The following is a description of a gene set: species: Mus musculus Any process that stops or reduces the rate of peptidase activity, the hydrolysis of peptide bonds within proteins. Mouse Gene Set: GOBP_NEGATIVE_REGULATION_OF_PEPTIDASE_ACTIVITY, and this is the list of marker genes: Csta1, Gapdhrt2, Serpinb9f, Serpinb8, Cst3, Stfa3, Bin1 (bridging integrator 1), Ecm1, Serpinb6a, Serpinb1c, Spock3, Wfdc6a, Serpinb9b, Timp2, Gapdh, Spink1, Gapdh-ps15, Cstdc4, Serpinb9e, Park7, Stfa1, Vtn (NCBI Gene Id 22370), Serpinb6c (serine (or cysteine) peptidase inhibitor, clade B, member 6c), Timp1, Ubxn1, Stfa2, Timp3, Tmed10, Cstdc6, Reck, Serpinb13, Csta3, Spink2, Cstdc3, Csta2, Serpine1, Akt1, Fetub, Stfa2l1, Eppin, Serpinb9h (serine (or cysteine) peptidase inhibitor, clade B, member 9h), Serpinb9c, Serpinb6b, Spink6, Cst7, Serpinb9, Gapdhrt, Serpinb6d, Spock1, Crb2, Serpinb6e, Serpinb9g, Spink5, Serpine2 (serine (or cysteine) peptidase inhibitor, clade E, member 2), Serpinb9d, Serpinb1b, Cstb, Cast (calpastatin), Serpinb1a, Cstdc5